The following is a description of a gene set: from publication Min L, Isa SA, Fam WN, Sze SK, Beretta O, Mortellaro A, Ruedl C (PMID 22250091) Genes down-regulated in bone marrow-derived dendritic cells CSF2 versus CSF2 and low dose of 1,3-beta-D-oligoglucan. species: Homo sapiens A simultaneous engagement of different pathogen recognition receptors provides a tailor made adaptive immunity for an efficient defence against distinct pathogens. For example, cross talk of TLR and c-type lectin signalling effectively shapes distinct gene expression patterns by integrating the signals at the level of NF-κB. Here, we extend this principle to a strong synergism between the Dectin-1 agonist, curdlan, and an inflammatory growth factor, GM-CSF. Both together act in synergy in inducing a strong inflammatory signature which converts immature DCs to potent effector DCs. A variety of cytokines (IL-1β, IL-6, TNF-α, IL-2 and IL-12p70), costimulatory molecules (CD80, CD86, CD40 and CD70), chemokines (CxCl1, CxCl2, CxCl3, CCl12, CCl17) as well as receptors and molecules involved in fugal recognition and immunity such as Mincle, Dectin-1, Dectin-2 and Pentraxin 3 are strongly up-regulated in DC treated simultaneously with curdlan and GM-CSF. The synergistic effect of both stimuli resulted in strong IKBα phosphorylation, in its rapid degradation and in enhanced nuclear translocation of all NF-κB subunits. We further identified MAPK ERK, as one possible integration site of both signals, since its phosphorylation was clearly augmented when curdlan was co-applied with GM-CSF. Our data demonstrate that the immunomodulatory activity of curdlan requires an additional signal provided by GM-CSF to successfully initiate a robust β-glucan specific cytokine and chemokine response. The integration of both signals clearly prime and tailor a more effective innate and adaptive response against invading microbes and fungi. Human Gene Set: GSE32986_GMCSF_VS_GMCSF_AND_CURDLAN_LOWDOSE_STIM_DC_DN, and this is the list of marker genes: ZBTB40, INTS6L (NCBI Gene Id 654032, integrator complex subunit 6 like), SNORA27, PIAS1, RPS3A, STN1, CAMK1D, PILRB, TSC22D3, CENPV, SLC38A6, BTBD9, EFCAB13, OR52N4, POLI, MPP1, ZNF91, RYK, TTN, DHRS3, WDR27, DHX58, BCL2, PTK2, TMEM182, RALGPS2, RPS8, RASGRP2, TMEM220, WNT7A, SNRK, PHF1, LFNG, NOSIP, IFIT1, RPS27A, TSPAN18, PLXDC1, OLFM2, KLF12, CD55, ZBTB18, AK5, TPM2, ZCWPW1, SULT1A1, SBF2, RASA2, ENGASE, EPB41L4A-AS1, CASP10, SNORA75, SCARNA17, KANSL2, SARAF, APBA2, PPFIBP2, SMARCA1 (NCBI Gene Id 6594), EML5, NPAT, OXNAD1, IPCEF1, TPH1, ATP1A1, TCF7, ITGA6, SNRPA1, PRKCA, MORN1, JADE1, CHMP7, MYLIP, RGCC, NFKBIZ, WWC2, ITGA5, ZMAT1, TNFRSF10D, GCSAM, PER2, TGFBR2 (transforming growth factor beta receptor 2), SNORD102, RPL9, PDK1, ALMS1, PTPRO, ZDHHC15, MBNL1 (muscleblind like splicing regulator 1), ITPKB, PLPP6, NDRG2, GPRASP1, RPS20, RBMS1, PLAC8, ZBTB20, CYB5D1, BEX5, SLC25A37, ZNF442, SPTBN1, TTC27, TTBK2, HAUS5, ZNF485, SLC4A5, SUPT3H, ERMN, ZNF626, ZCCHC14, TNFRSF10A, RPL37A, ARHGEF1, EPHA1, GABBR1, PCED1A (PC-esterase domain containing 1A), JADE2, SIN3B, NOG, ZNF331 (zinc finger protein 331), RIMKLB, NOL4L, RPL30, ACVR1C, ZNF204P, SYDE2, TPCN1, SVIL, LEPROTL1, SECISBP2, FLACC1, MAN1C1, SCML1, DNMT3A, ZMYND8, GAL3ST4, LINC03009, DGKD, MAML2, PEX3, GCDH, REX1BD, LINS1, NCK2, SNORD4A, FAM86DP, DDX31, ANGEL1, CCDC180, PXYLP1, TCEA3, SBDS, CFAP44, REV1, FNBP4, KAT6A, TOP1MT, PLCL1, KPNA5, CUBN, IQCN, ZNF223, SH2D3A, DTWD2 (DTW domain containing 2), PECAM1, ADD2, CFAP68, TXK, PSMG4, FOXP1, SNORD61, LETMD1, CACHD1, KLF2, MSX2P1, RBM8A, AMIGO1, LDLRAP1, TSPAN6, ARHGAP32, DYNLT3, MPP7, RNF157, DNAJB1, RPL5, MDS2, SSH2, NKAPP1, RPL34, INPP5A, RHBDD1, XKRX, TRMT13, RBM19, RETREG1, NUAK2, ZNF337